The following is a description of a gene set: Human Gene Set: HP_SPLIT_NAIL A nail plate that has a longitudinal separation and the two sections of the nail share the same lateral radius of curvature. species: Homo sapiens Split nail, and this is the list of marker genes: GTF2H5, GTF2E2, TARS1, CARS1 (NCBI Gene Id 833), EFNB1, AARS1, MPLKIP, DKC1, ERCC2, ERCC3, RNF113A